Given this list of marker genes TMEM132B, SEMA4G, SEMA6A, R3HDM2, SYN1, ZNF138, IGF2, INKA2, PTK7, ADD1, MN1, SRD5A3, SHCBP1L, EMX2, PRSS33, PSME3, ERF, TNKS1BP1, REEP5, DIRAS2, ASGR2, SCGB2B2, STN1, AGPAT1, NTSR1, DNMT3A, CORIN, CYP26B1, KCNS2, SLC44A1, ARRB1, MARK4, DIP2B, F11R, DPP8, FBXO41, DVL3, PCBD1, KNTC1, G6PC2, TRNP1, DMGDH, RIMOC1, HIF3A, SPATA31D4, here is a description of the gene set: Human Gene Set: MIR6742_5P from publication Chen Y, Wang X (PMID 31504780) species: Homo sapiens Genes predicted to be targets of miRBase v22 microRNA hsa-miR-6742-5p in miRDB v6.0 with MirTarget v4 prediction scores > 80 (high confidence targets).